The following is a description of a gene set: species: Mus musculus Mouse Gene Set: GOBP_NEGATIVE_REGULATION_OF_MAMMARY_GLAND_EPITHELIAL_CELL_PROLIFERATION Any process that stops, prevents or reduces the rate or extent of mammary gland epithelial cell proliferation., and this is the list of marker genes: Phb2, Gata3, Brca2, Robo1, Zfas1, Etv4, Cdkn2a